The following is a description of a gene set: electronically inferred by orthology from the curated human pathway studied in species Mus musculus Reactome Pathway: Nuclear Events (kinase and transcription factor activation) This event has been computationally inferred from an event that has been demonstrated in another species.<p>The inference is based on the homology mapping from PANTHER. Briefly, reactions for which all involved PhysicalEntities (in input, output and catalyst) have a mapped orthologue/paralogue (for complexes at least 75% of components must have a mapping) are inferred to the other species. part of: Signaling by NTRK1 (TRKA), and this is the list of marker genes: Ppp2r1b, Sgk1, Vrk3, Egr2, Ppp2r5d, Dusp6, Rps6ka5, Mapk3, Mapk14, Dusp7, Mapk11, Mapk7